The following is a description of a gene set: Human Gene Set: HP_CEREBRAL_CORTICAL_HEMIATROPHY Cerebral cortical hemiatrophy Atrophy of one side of the brain, characterized by findings including thinning of the cerebral cortex, reduced volume of the cerebral white matter with abnormal myelination, and enlargement of the ispilateral fourth ventricle. species: Homo sapiens, and this is the list of marker genes: MBTPS2, TCTN3, MYO5A, ACTB, EHMT1, ACTG1